Given this list of marker genes CDC42, RHOA, KLC1, KLC3, KLC2, KTN1, KIF5A, KLC4, KIF5B, RAC1, RHOG, here is a description of the gene set: GTP-bound active forms of RHO GTPases RHOA, RHOG, RAC1 and CDC42 bind kinectin (KTN1), a protein inserted in endoplasmic reticulum membranes that interacts with the cargo-binding site of kinesin and activates its microtubule-stimulated ATPase activity required for vesicle motility. The effect of RHOG activity on cellular morphology, exhibited in the formation of microtubule-dependent cellular protrusions, depends both on RHOG interaction with KTN1, as well as on the kinesin activity. RHOG and KTN1 also cooperate in microtubule-dependent lysosomal transport. The precise mechanism of kinectin-mediated Rho GTPase signaling cascade needs further elucidation, and only the first two steps, KTN1-activated RHO GTPase binding, and KTN1-kinesin-1 binding are annotated here. Reactome Pathway: RHO GTPases activate KTN1 part of: RHO GTPase Effectors species: Homo sapiens